Given this list of marker genes Clcn2, Dab2, Ggcx, Prkg1, Dkk3, H6pd, Ppargc1a, Pptc7, Bglap, Akr1c18, Bmp6, Bglap2, Rest, Bmp2 (bone morphogenetic protein 2), Dgkq, Sirt5, Bmp5, Dkkl1, Cmtm2a, Adck2 (NCBI Gene Id 57869), Egr1, Gprc6a, Creb1, Wnt4, here is a description of the gene set: species: Mus musculus Any process that modulates the frequency, rate or extent of the chemical reactions and pathways resulting in the formation of a ketone, carried out by individual cells. Mouse Gene Set: GOBP_REGULATION_OF_KETONE_BIOSYNTHETIC_PROCESS